Given this list of marker genes Gak, Cltc, Dnajc6, Hspa8, Vps4a, Synj1, here is a description of the gene set: species: Mus musculus Mouse Gene Set: GOBP_VESICLE_UNCOATING A protein depolymerization process that results in the disassembly of vesicle coat proteins.